Given this list of marker genes MAP4K2, TMEM63A, TMEM19, WASHC2A, CIAO2A, SYNGR1, NR2C2AP, RAB5IF, SINHCAF, HMGB1, KLHL6-AS1, PPTC7, ADA2, SLC2A6, MCOLN2, PKHD1L1, NAA50, ELOF1, RPL35, BAIAP3 (BAI1 associated protein 3), NME1-NME2, NRROS, HIBCH, SLC17A9, CYP20A1, ADGRE5, ZNF138, LINC00996, ZNF107, DR1, DBF4, THUMPD1, PCED1B, UBE2E2, RACK1, SNX10, GRIPAP1 (NCBI Gene Id 84538), TPT1, DOP1B, RPL5, STK38, STK10, PRXL2C, TIFA, LINC00513, APOBEC3G, HDAC10, MOB4, ARPC1B, CDC40, ANKZF1, IDI1, NPAT, RCOR3, DLEU1, USP48, LRBA, S1PR4, EBP, SETDB2, FGD3, COMMD6, RASSF5, HSP90AB1, MITD1, SS18L2, GATA2, PPP1CA, GCA, LINC01857, TLK2, IRAK2, CENPM, TRAPPC10, RBM38 (RNA binding motif protein 38), CD86, PEA15, TRIM4, TMEM273, LAX1, SEPTIN1, HADH, TBRG1, DMXL1, H2AC18, RNF168, SSNA1, here is a description of the gene set: Occular cell types curated from Gautam and Hamashima et al. Multi-species single-cell transcriptomic analysis of ocular compartment regulons from publication Gautam P, Hamashima K, Chen Y, Zeng Y, Makovoz B, Parikh BH, Lee HY, Lau KA, Su X, Wong RCB, Chan WK, Li H, Blenkinsop TA, Loh YH (PMID 34584087) Human Gene Set: GAUTAM_EYE_IRIS_CILIARY_BODY_CYTOTOXIC_T_CELLS species: Homo sapiens